The following is a description of a gene set: studied in species Homo sapiens Human Gene Set: WP_HDAC6_INTERACTIONS_IN_THE_CENTRAL_NERVOUS_SYSTEM HDAC6 interactions in the central nervous system, and this is the list of marker genes: TUBA3C, POU5F1, MAPK8, HSPA4 (heat shock protein family A (Hsp70) member 4), VCP, BBIP1, NR3C1, HTT, HDAC9 (NCBI Gene Id 9734), NEDD9, GRIA1, MAP3K5, MAP1LC3A, RAC1, DYNC1I2 (dynein cytoplasmic 1 intermediate chain 2), TUBB3, BAX, APC, EGFR, HIF1A, MAP1B, FOXP3 (forkhead box P3), CTNNB1, EP300, MYH9, DCTN1, MAPK3, CNOT6, PRDX1, HDAC6, XRCC6, HSP90AA1, MIIP, PXN, PROM1, APOE (NCBI Gene Id 99), CDC20, TUBA1C, PARK7, AURKA, HSPA8 (NCBI Gene Id 3312), ERG, VIM, PRKN, MIF, PRDX2, CTTN, SIRT2 (sirtuin 2), GSK3A, PRKCE, SP1, VHL, G3BP1, ELP1, EP400, MAPRE1, ITIH4, SGK3, STUB1, TPPP, GSK3B, TUBA4A, HSF1, NDUFV1, CCDC141 (coiled-coil domain containing 141), MDH1, MAPK1, BCL2, CSNK2B (casein kinase 2 beta), PTK2B (NCBI Gene Id 5748), HSPB1, SNCAIP, SHH, DLG2, TWIST1, PPP1CA, FUS, BIRC5, MAPT, DLG4, MYD88, SQSTM1, GRK2, ARID3A, OPTN, SMAD2, UBD, KAT5, CSNK2A2, RAD23B, RHOT1, TRIM50, AKT1, PRKCZ, DNAJA1, SGK1, KALRN, ACTR1A (actin related protein 1A), SOD1, TARDBP, ELP3, SMAD7, CYBB, HDAC11, CFTR, TUBB, ATP13A2, SNCA, ISG15, GARS1, GRIA2, BDNF, ATXN3